Given this list of marker genes ERI1, WASF1, SVBP, COX4I1, ADNP, TBX3, here is a description of the gene set: Short 4th toe Human Gene Set: HP_SHORT_4TH_TOE studied in species Homo sapiens Underdevelopment (hypoplasia) of the fourth toe.